The following is a description of a gene set: Human Gene Set: REACTOME_AZATHIOPRINE_ADME species: Homo sapiens Azathioprine ADME, and this is the list of marker genes: HPRT1, IMPDH1, VAV1, GMPS, RAC1, GSTA2, NUDT15, GUK1, SLC28A2, SLC28A3, SLC29A2, VAV3, NME2, ABCC5, GSTM1, IMPDH2, SLC29A1, VAV2, XDH, GSTA1, TPMT, ABCC4, NME1